Given this list of marker genes CD6, BCL11B, CCR7, CD28, SASH3, GPSM3, CD79B, SHISAL2A, ENSG00000259097, TXK, CTSW, TRAT1, MYO1G, CD2, LINC02328, CD69, CHI3L2, AGAP2, TAP2, GVINP1, SCML4, CD3D, RASAL3, SEPTIN1, MS4A1, TMIGD2, MFNG, EPHA1-AS1, PTPN7, RAC2, LAT, TRBC2, PYHIN1, ITK, PTPRCAP (NCBI Gene Id 5790), THEMIS, TBC1D10C, SIRPG, STAT4, LCK, CD5, ICAM3, TRAF3IP3, PCED1B-AS1, LEF1, OAS2, IGHM, GATA3, SH2D1A, IL21R, LTA, ICOS, CD79A, NIBAN3, SAMD3, NKG7, SELL, LINC01934, S1PR4, IL2RB, FAM78A, GZMM, TCF7 (NCBI Gene Id 6932), ZAP70, TMC8, CD7, IL7R, ZNF831, GZMA, CD52, PRKCQ, CD3G, LTB, SKAP1, CD27 (NCBI Gene Id 939), CORO1A, KLRB1, CD247 (NCBI Gene Id 919), BACH2 (BTB domain and CNC homolog 2), PAX5, CD3E, RASGRP2, MATK, here is a description of the gene set: from publication Cao J, O'Day DR, Pliner HA, Kingsley PD, Deng M, Daza RM, Zager MA, Aldinger KA, Blecher-Gonen R, Zhang F, Spielmann M, Palis J, Doherty D, Steemers FJ, Glass IA, Trapnell C, Shendure J (PMID 33184181) studied in species Homo sapiens The gene expression program underlying the specification of human cell types is of fundamental interest. The study authors generated human cell atlases of gene expression and chromatin accessibility in fetal tissues. For gene expression, the study authors applied three-level combinatorial indexing to >110 samples representing 15 organs, ultimately profiling ~4 million single cells. The study authors leveraged the literature and other atlases to identify and annotate hundreds of cell types and subtypes, both within and across tissues. Our analyses focused on organ-specific specializations of broadly distributed cell types (such as blood, endothelial, and epithelial), sites of fetal erythropoiesis (which notably included the adrenal gland), and integration with mouse developmental atlases (such as conserved specification of blood cells). These data represent a rich resource for the exploration of in vivo human gene expression in diverse tissues and cell types. Marker genes curated from the annotated cluster as represented in the Descartes Human Gene Expression During Development database. Human Gene Set: DESCARTES_FETAL_STOMACH_LYMPHOID_CELLS